The following is a description of a gene set: from publication de Freitas A, Banerjee S, Xie N, Cui H, Davis KI, Friggeri A, Fu M, Abraham E, Liu G (PMID 22573805) Human Gene Set: GSE36891_UNSTIM_VS_POLYIC_TLR3_STIM_PERITONEAL_MACROPHAGE_UP Genes up-regulated in peritoneal macrophages: untreated versus poly(IC). studied in species Homo sapiens We have identified more than genes that have upregulated expression in TLR3 activated (PMI-1,2), but have downregulated expression in TLR2 activated (PMP-1,2) macrophages, as compared to control cells (PMC-1,2), and this is the list of marker genes: KCNE4, DUSP4, PI15, HSPA1A, APOLD1, ART4, CABP7, NR4A1, MIR145, CXCL1, PTGS2, DYRK3, SEMA4C, DAZL, SLC25A25, HSD17B6, ADAM12, TNFAIP6, TOB2, DOK7, WT1, MAFF, FOS (Fos proto-oncogene, AP-1 transcription factor subunit), H1-1, FAM117A, NR4A2, REL, LRP8, PARD6A, EGR1, PMAIP1, FGF23, DPF3, S100A14, RND2, CCRL2, MNT, CXCL2, NEURL3, PEG10, GPX6, EVC2, PELO, IRS2, EDN1, EGF, DNAJB4, SLC25A33, EGR3 (NCBI Gene Id 1960), ELFN1, GDAP1, CTLA4, DUSP8, TRPC6, COQ10B, CHTF18, SDC4, TGFB2, WNT11, NFIL3, PLA2G2A, GPR22, SV2A, KCND1, SPRY2, FGFRL1, TMCC3, KCTD12, KRT6A, PPP1R15A, IER2, CYTIP, PLK3, ENC1, STRA8, EGR2, IGSF9, IMPACT, TNFRSF19, MYOZ3, PCP4, PDZK1IP1, SPRY1, MAMDC4, IL6, SLC6A11, PHLDA1, PBX4, INTS5, HMGCLL1 (3-hydroxy-3-methylglutaryl-CoA lyase like 1), NGF (NCBI Gene Id 4803), FOXD1, ASIC5, MAGIX, ADAMTS1, GPR132, DUSP5, NFKBIZ, CCL2, ZFP36, BTN1A1, SERPINE1, MUCL1, FOSL2, TNFAIP2, BTG2, PLK2, HTR2A, HAMP, CEACAM3, NR4A3, IER3, AREG, IL17C, NGFR, MIR23A, BSDC1, KCNJ1, KRT36, TBX3, ATF3, HEPH (hephaestin), GNGT1, PROCR, RSPH4A, ODC1, REC8, HOMER1, HES2, NEFL, RASD1, TRIM45, TMEM8B, AKAP12, LIF, PAK4, IPO4, CEBPB, CCL7, TNFAIP3, CEBPD, FOSB (NCBI Gene Id 2354), SOWAHC, ARL4D, NRG1, ADAMTS9, CSHL1, KDM6B, TRIM75